The following is a description of a gene set: Genes down-regulated in skin with IL1R1 knockout: uninfected versus S. aureus infection. Neutrophil abscess formation is critical in innate immunity against many pathogens. Here, the mechanism of neutrophil abscess formation was investigated using a mouse model of Staphylococcus aureus cutaneous infection. Gene expression analysis of S. aureus-infected skin revealed that induction of neutrophil recruitment genes was largely dependent upon IL-1beta/IL-1R activation. Unexpectedly, using IL 1beta reporter mice, neutrophils were identified as the primary source of IL-1beta at the site of infection. Furthermore, IL-1beta-producing neutrophils were necessary and sufficient for abscess formation and bacterial clearance. S. aureus-induced IL 1beta production by neutrophils required TLR2, NOD2, FPRs and the ASC/NLRP3 inflammasome. Taken together, IL-1beta and neutrophil abscess formation during an infection are functionally, spatially and temporally linked as a consequence of direct IL-1beta production by neutrophils. Human Gene Set: GSE36826_NORMAL_VS_STAPH_AUREUS_INF_IL1R_KO_SKIN_DN species: Homo sapiens from publication Cho JS, Guo Y, Ramos RI, Hebroni F, Plaisier SB, Xuan C, Granick JL, Matsushima H, Takashima A, Iwakura Y, Cheung AL, Cheng G, Lee DJ, Simon SI, Miller LS (PMID 23209417), and this is the list of marker genes: TRPS1, TDP1, CARD8, RTN3, SORL1, PLCB2, NAB1 (NGFI-A binding protein 1), RNASE6, RXRA, GSAP, PAPSS1, GMIP, SPG21, ADAM10, PTPN22, RPS3, PLPBP, SFXN3, GABARAP, XPOT, SLC16A6, OTULINL, ZCCHC14, GNB1, GID8, VAV1, RNF41 (NCBI Gene Id 93069), SLC4A7, ADSS2, RCBTB2 (NCBI Gene Id 1102), CCL22, COPZ1, TM6SF1, HLA-DQB1, GALC, CBX5, FOS, LRP8, RUFY2, LRRC8D, NACA, RPS23, AGO1, TALDO1, SYK, GIGYF2, SYNE3 (spectrin repeat containing nuclear envelope family member 3), HNRNPA3, ALDOA, ATRN, PCMT1, CERK, TRMT5, IRAK1, METTL9, SLC38A2, HERPUD1, LBR, ATP6V0B, PAGR1, LORICRIN, HMGN2, HSD17B10, IFFO1, TLR5, PXN, ABHD17A, WDR26, RNASE4, ILF3, RPL41, PPP1R14B, U2AF1, CHP1 (NCBI Gene Id 11261), ZFP36L2, ZFAND5, ACSL5, SATB1, CST7, PACSIN2, PPP3CA, DYM, ITGAE, ALOX5AP, RASA1, TPST2, RPL8, ABCD3, KCTD7, MAP3K4, CD58, SH3BGRL3, CD37, RPS9, SH3GL1, PITPNA, ARL4C, STK38L, S100P, MPP1, MAP4K3, CALM2, EIF3L, SETD3, NPL, DIAPH1, THBS1, FPR1, CEP85, ZMIZ1, UNC119B, MYCL, PDE4A, CXCR4, FLNA, HCCS, TFEB, TM9SF1, USP4, PDLIM7, ZMYM1, SMC4, FAU, GLT8D1, S100A12, AMPD2, SELENOT, BICD2, PEA15, GPR35, ANP32A, SERF2, DNMBP, HLA-DPB1, RPL27, ADK, CALR, TCIRG1, MAP3K3, CSF1R, REV3L, IFNGR1, GPATCH2L, LCP1, EREG, RNH1, RPL7, LPXN, ZNF706, CPPED1, CLDND1, VPS13D, PYCARD, SLC3A2, PICALM, COTL1, SLC11A1, HSP90B1, INTS8, OSBPL11, KRT10, POR, GMCL1, TULP4, POLR2L, FBXW7, CYP27A1, C5AR2, PCGF3, SARAF, EMP1, HTT, TGFBI, RHOB, ARF5, KIAA0232, NONO, TMEM230, BRD3, SEC63, TACC3 (transforming acidic coiled-coil containing protein 3), USP34, TTLL4, ANXA2, AKAP17A, AP1S2 (adaptor related protein complex 1 subunit sigma 2), RPS4Y1, PTGS1, TGIF1, RNFT1, EGR2, SERP1, VAMP4, SSR2 (signal sequence receptor subunit 2), CYTIP, ZFC3H1, ATP6V0D1, AHNAK, SH2B3